The following is a description of a gene set: Human Gene Set: GOBP_REGULATION_OF_POSTSYNAPSE_ASSEMBLY Any process that modulates the frequency, rate or extent of postsynapse assembly, the aggregation, arrangement and bonding together of a set of components to form a postsynapse. species: Homo sapiens, and this is the list of marker genes: S1PR2, ASIC2, SEMA4C, CC2D1A, ASIC1, ELMO1, ZDHHC8, CRMP1, CYFIP2, RHOG, DOCK4, DOCK10, VPS35, HTR4, SLC12A5, NUMBL, UBE2M, ARHGEF15, ARHGAP12, MARK1, SYNDIG1, RAC3, CARMIL3, GNA13, LZTS1, NCKIPSD, NAE1, NEDD8, UBE3B, PPP1R9B, NEURL1, ARHGAP33, TRIM47, PUM2 (NCBI Gene Id 23369), PTPN1, LRP4, RAC1, RTN4R, SENP1, DOCK1, NRXN2, NECTIN3, MAP1B, SIGMAR1, RTN4